The following is a description of a gene set: Reactome Pathway: Resistance of ERBB2 KD mutants to AEE788 This pathway describes resistance of ERBB2 KD mutants to tyrosine kinase inhibitor AEE788. species: Homo sapiens part of: Drug resistance in ERBB2 KD mutants, and this is the list of marker genes: ERBIN, CDC37, ERBB2, HSP90AA1